The following is a description of a gene set: Human Gene Set: HP_ABNORMAL_PALM_MORPHOLOGY An abnormality of the palm, that is, of the front of the hand. species: Homo sapiens Abnormal palm morphology, and this is the list of marker genes: MBTPS2, RAB11B, NUP88, LMNA, MRPS28, HDAC6, IFT122, KANK2, PEX11B, SLC18A3, SERPINA12, PEPD, NPAP1, NGLY1, KRT14, EBF3, SLC25A24, ALOXE3, SMC1A, NAA10, TRAPPC11, KRT10, COL11A2, CILK1, ZC4H2, RSPRY1, TBX4, FOXP1, TRIM37, TRPS1, EHMT1, B3GLCT, PDGFRB (NCBI Gene Id 5159), KRT6A, KCNN3, ALDH6A1, RECQL4, HDAC4, ATP6V1B2, TUFT1, TERT, IFT57, TCF12, DSG1, SPRTN, CFTR, MUSK, WNT5A, ATP7A, MAPK1, GLE1, CTBP1, NHP2, TOE1, TNNT3, STS, MTFMT, LTBP4, PNPLA6, GPX4, DST, CD96, KRT5, KLK11, KRT2, TGM5, SNORD115-1, CDK10, BHLHA9, RAPSN, NPM1, KRT85, VPS33B, WDR35, LORICRIN, RAB23 (RAB23, member RAS oncogene family), PEX10, LAMB3, PTEN, ARL3, RNU4-2, ACVRL1, SDHC, MYOD1, GDF5, UBR7, TUBA1A, PIK3R1, CHST14, FILIP1, RPS6KA3, KRT1, WAC, AUTS2, CHD7, CHSY1, GLYCTK (NCBI Gene Id 132158), DPM1, PKDCC, PTCH2 (patched 2), FZD2, H3-3A, DYNC1H1, PORCN, ATR, NDN, ASXL2, DSC2, GPR35, PGM2L1, PSENEN, CTSC, PIGL, KLHL15, SMARCA2, TRPV4, MED12, FGFR1, MCOLN1, TERC, JUP, TOMM7, SASH1, TNFRSF1B, LTBP1, MED25, TAF6, SMPD4, TSEN34, DLK1, ZMYM2, KDM6A, NEK1, SOX18, PTCH1, SPRED2, SMS, EVC, KRT74, DIS3L2, ADAMTSL1, ABCA12, VPS33A, RIN2, TGDS, ITGB4, FBXO28, CAST, SHOC2, MTOR, NEXMIF, VPS51, LAMA3, KCNJ2, CTCF, KRAS (NCBI Gene Id 3845), CST6, MAP2K1, TYMS, SH3PXD2B, VAC14, CTSB, FLII, PRKAR1A, WRAP53, PRR12, DYNC2H1, SRD5A3, TBL1XR1, ATP6V0A2, RPL10, TAF4, SLC2A10, USB1, INPPL1, BRD4, HNRNPR, RHBDF2, CPLX1, SIN3A, ITCH, USF3, DVL3, CRLF1, DPYD, RERE (NCBI Gene Id 9642), SMC5, PEX12, IGF1R, RIPK4, RIT1, TSEN15, CHST3, GMPPA, CARD14, BMP4, CSGALNACT1, LAMC2, CLCN7, MAP1B, PEX13, GJB3, ERI1, COL17A1, ADNP, PPP1R13L, CD4, ESCO2, SMC3, COL2A1, PEX2 (NCBI Gene Id 5828, peroxisomal biogenesis factor 2), CAMTA1, CIB1, EZH2, ENPP1, PIGS, RPS23, VPS13B, GNS, GJA8, BMPR1B, DLX4, PPP3CA, COL14A1, PEX19, IHH, PLEC, WDR81, EXTL3, TINF2, PEX16, POMP (NCBI Gene Id 51371), BCR, HCCS, KRT6C, CYP4F22, UBE3B, BICD2, SIL1, TMEM53, TRPV3, FHL1, LTBP3, SNAP29, SLCO2A1, CSTA, NBAS, CREBBP (NCBI Gene Id 1387), HERC2, DDR2, FGF9, YY1, NOG, IVNS1ABP (NCBI Gene Id 51489), RAB3GAP2, PIEZO2, UFC1, LIFR, CUL4B, TELO2, TBCE, MST1, TNNI2, KRT83, SCUBE3, PWRN1, PWAR1, TPM2, RTL1, BRF1, CRKL, PEX1, KLLN, KATNB1, TBX5, PLOD3, ZNF462, KCNK9, NECTIN1, POGLUT1, DSP, NLRP1, RMRP, NSDHL, HNRNPK, TSEN2, TONSL, UPF3B, SDHB, POLR1A, SULT2B1, IFT80, DKC1, MEF2C, CDSN, MTX2, BCOR, LZTR1, COG1, RBPJ, PPP2R3C (protein phosphatase 2 regulatory subunit B''gamma), MBD5, TMEM147, IGF1, CTC1, ORC1, COL11A1, CD28, CERS3, SRRM2, FERMT1, SNORD116-1, PEX6, PIGA, DEPDC5, DVL1, KRT17, TRIO, ALOX12B, TCF4, IFT43, DOCK6, ATP2A2, PEX5, GNB2, SEC23B, DYM, RAD21, NUP107 (NCBI Gene Id 57122), IQSEC2, AQP5, GJB2, AIFM1, SNRPN, SLC25A12, EP300, LBR, MEG3, MCTP2, TRIP11, STAG1, GJB4 (NCBI Gene Id 2708), KDSR, PTDSS1, CSNK2A1, POLRMT, GJA5, TRPM4, TFAP2A, COX7B, TBCK, MSL3, FIG4 (NCBI Gene Id 9896), AKT1, SNIP1, NIPBL, KDM6B, XYLT1, MAP3K7, DPH2, CDC42BPB, MEGF8, ADAMTS10, G6PC3, ASXL1, WNT10A (Wnt family member 10A), PEX14, RBM10, SLURP1, FGFR2, ARID1B, CEP57, TASP1, TRIM8, FGFR3, DHX30, SUFU, STXBP1, FGD1, CTLA4, BRAF, KLHL24, SEMA4D (NCBI Gene Id 349236), NDUFB11, TP63, PLOD1, KCNH1, COL7A1, NAA20, PPP2CA, MAP2K2, PTH1R, PKP1 (NCBI Gene Id 5317), UBR1, ROR2, C1R, BGN, FBXO11, PTPRF, RSPO1, AAAS (NCBI Gene Id 8086), KRT9, ZNF292, FGFRL1, DOK7, DPAGT1, ZFX, TGM1, SERPINB7, SMAD2, SMARCAD1, GPC4 (NCBI Gene Id 2239), PEX26, PDHA1, SET, AFF3, COG4, FLG, NOP10, ZNF469, SDR9C7, KRT6B, ASXL3, RNU4ATAC, HDAC8, RTEL1, GPC3, ANTXR2 (ANTXR cell adhesion molecule 2), HRAS, GRHL2, MKRN3, GRIN1, COX14, KDM5C, KDF1, ATP6V1A, LMX1B, CKAP2L, TAT, DYNC2I2, GJA1, SEPSECS, GNB1, CDK19, AAGAB, COL9A2, RAI1, DPH1, MYH3, FLNA, AHDC1, PEX3 (NCBI Gene Id 8504), PIK3CA, SLC39A13, TWIST1, COG6, DDX11, PUF60, WDR37, CCNQ, KANSL1, EXT1, HPGD, KMT2B, AP1B1, U2AF2, THOC2, SMOC1, LSS, PLAA, POFUT1 (NCBI Gene Id 23509), LONP1, CEP55, JARID2, LETM1, DYNC2I1, FBN1, AIP, APC, EVC2, NUP188, SDHD (NCBI Gene Id 91899), PACS1, ANKRD11, SLC35C1, KRT16, MAGEL2, NIPAL4, OTUD5, GPR101, NALCN, NSD2, ADAMTSL2, TSEN54, SPTBN1, PARN, CAMK2G, KMT2D, H4C9, DEAF1, DSE, KAT6B, NECTIN4, SPECC1L, MAPRE2, POR, CCBE1, YY1AP1, SETBP1 (SET binding protein 1), NXN, MMP1, KIF21A, PNPLA1, GJB6, KDM4B, PERP, SMAD4, MRAS, DPYSL5, B4GALT7, DLG5, ADAMTS15